The following is a description of a gene set: In this study, we provide a molecular signature of highly enriched CD34+ cells from bone marrow of untreated patients with chronic myelogenous leukemia (CML) in chronic phase in comparison with normal CD34+ cells using microarrays covering genes. Expression data reflected several BCR-ABL-induced effects in primary CML progenitors, such as transcriptional activation of the classical mitogen-activated protein kinase pathway and the phosphoinositide-3 kinase/AKT pathway as well as downregulation of the proapoptotic gene IRF8. Moreover, novel transcriptional changes in comparison with normal CD34+ cells were identified. These include upregulation of genes involved in the transforming growth factorbeta pathway, fetal hemoglobin genes, leptin receptor, sorcin, tissue inhibitor of metalloproteinase 1, the neuroepithelial cell transforming gene 1 and downregulation of selenoprotein P. Additionally, genes associated with early hematopoietic stem cells (HSC) and leukemogenesis such as HoxA9 and MEIS1 were transcriptionally activated. Differential expression of differentiation-associated genes suggested an altered composition of the CD34+ cell population in CML. This was confirmed by subset analyses of chronic phase CML CD34+ cells showing an increase of the proportion of megakaryocyte-erythroid progenitors, whereas the proportion of HSC and granulocyte-macrophage progenitors was decreased in CML. In conclusion, our results give novel insights into the biology of CML and could provide the basis for identification of new therapeutic targets. from publication Diaz-Blanco E, Bruns I, Neumann F, Fischer JC, Graef T, Rosskopf M, Brors B, Pechtel S, Bork S, Koch A, Baer A, Rohr UP, Kobbe G, von Haeseler A, Gattermann N, Haas R, Kronenwett R (PMID 17252012) species: Homo sapiens Genes down-regulated in CD34+ cells isolated from bone marrow of CML (chronic myelogenous leukemia) patients, compared to those from normal donors. Human Gene Set: DIAZ_CHRONIC_MYELOGENOUS_LEUKEMIA_DN, and this is the list of marker genes: GPR137B, S100A9, ANXA5, ANK3, ELANE, CCR2, VPREB1, SORL1, TLR2, SH3BP4, CEBPD, ISG20, CD53, IFI30, KLF4, IRF8, LY86, FCGR1A, BCL6, HLA-B, BTG2, EPB41L3, GADD45B (NCBI Gene Id 4616), LILRB3, TERT, RPS15, PROM1, FGL2, MN1, SLC16A7, SELL, CCR7, GAPDH, EEF1A1, DACT1, RPS11, RPL18A, FLT3, FAAH, KLF2, SLC1A3, ZNF124, MYOF, FGFR1, CDH2, NINJ1, VAMP5, LILRB4, RPLP1, LHFPL6, HERC5, ADAP2, IRF7, TGFBI, RPL30, GATA3, CSTA, HMHB1, S100A8, GPX3, SATB1, BLNK, IL16, GSDME, IL7R, BCR, INSR, RPL32, ADD3, ADA2, SGCB, RPL41, MPO, MAFB, RPS17, MNDA, CSF1R, MVP, HAL (NCBI Gene Id 3034), ME1, PRNP, MYO18A, IL13RA1, OAS2, LPL, GAS7, MS4A4A, RPL39, NKG7, HLA-DMB (NCBI Gene Id 3109), IL10RA, MYLK, CLEC4A, FLNB, PTPRE, ADA, CRYGD, CLEC5A, GLIPR1, TCF7, CST7, MYO5C, ACTG1, F13A1, RPS24, RPL23A, MS4A6A, NOP53, CRHBP (NCBI Gene Id 1393), JAM2, RPS12, CAPN3, FZD2, MCL1, ACSL4, DNTT